Given this list of marker genes Eef2, Coa7 (NCBI Gene Id 69893), Serinc3, Lyz2, Naca, Npc2, Hpse, Cx3cr1, Klf2, Flt1, Cybb, Sat1, Lpl, Eef1a1 (eukaryotic translation elongation factor 1 alpha 1), here is a description of the gene set: from publication Cui A, Huang T, Li S, Ma A, Pérez JL, Sander C, Keskin DB, Wu CJ, Fraenkel E, Hacohen N (PMID 38057668) studied in species Mus musculus Cytokines mediate cell-cell communication in the immune system and represent important therapeutic targets. A myriad of studies have highlighted their central role in immune function, yet we lack a global view of the cellular responses of each immune cell type to each cytokine. To address this gap, the authors created the Immune Dictionary, a compendium of single-cell transcriptomic profiles of more than 17 immune cell types in response to each of 86 cytokines (>1,400 cytokine-cell type combinations) in mouse lymph nodes in vivo. A cytokine-centric view of the dictionary revealed that most cytokines induce highly cell-type-specific responses. For example, the inflammatory cytokine interleukin-1β induces distinct gene programmes in almost every cell type. A cell-type-centric view of the dictionary identified more than 66 cytokine-driven cellular polarization states across immune cell types, including previously uncharacterized states such as an interleukin-18-induced polyfunctional natural killer cell state. Mouse Gene Set: CUI_MONOCYTE_IL10_RESPONSE_DN Genes negatively differentially expressed in cell type: Monocyte upon treatment with cytokine: IL-10 in mouse lymph nodes in vivo.